The following is a description of a gene set: Abnormal epiphyseal ossification studied in species Homo sapiens Human Gene Set: HP_ABNORMAL_EPIPHYSEAL_OSSIFICATION An abnormality of the formation and mineralization of an epiphysis., and this is the list of marker genes: PEX10 (NCBI Gene Id 5192), PROP1, LHX3, TSHR, NEU1 (NCBI Gene Id 4758), CYP2R1, TRAPPC2, TRPV4, P4HB, PEX5, TONSL, PEX26, PEX7, COL1A1, SOX9, TSHB, DHCR7, KIAA0586, PAM16, PDE4D, PISD, VDR, COL1A2, SNRPB, DUOX2, PEX13, GNPAT, DDRGK1, MIR140, RTL1, PEX19, PEX1, COL9A3, DUOXA2, ESR1, FLNB, GUSB, SLC5A5, CSPP1, PEX2, MATN3, SLC34A3, DDR2, AGPS, BMPR1B, PEX6, ARSL, RNU4ATAC, TG, DYM, PEX12, B3GALT6, LONP1, GDF5, POU1F1, FGFR2, INPPL1, NSDHL, CLCN5, IYD, PEX16, PRKAR1A, KIF7, PEX3, GPX4, CYP19A1, HESX1, DLK1, LHX4, COL2A1, KIF22, IARS2, COMP, PEX14, THRB, KCNH1, PTH1R, GGCX, CYP27B1, MEG3, LBR, MGP, EBP, TPO, PEX11B (peroxisomal biogenesis factor 11 beta), VPS35L